The following is a description of a gene set: Mouse Gene Set: GOBP_PROTON_MOTIVE_FORCE_DRIVEN_ATP_SYNTHESIS species: Mus musculus The chemical reactions and pathways resulting in the formation of ATP driven by transport of protons across a membrane to generate an electrochemical gradient (proton-motive force)., and this is the list of marker genes: Ndufa1, Ndufab1, Ndufa7 (NADH:ubiquinone oxidoreductase subunit A7), Ndufa10, Ndufa6, Ndufb9, Sdha, Atp5mc2, Atp5f1e, Ndufb8, Ndufs2, Ndufv1, Ndufa12, mt-Nd2, Ndufb10, Ndufs1, Ndufs8, Ndufb6, Atp5f1a, Atp5f1c, Atg5lrt, Sdhc, Ndufa2, Atp5mc1, mt-Nd1, Ndufs5, Atp5f1d, Ndufs3, Ndufb5, Atp5pb, Ndufb1, Ndufa11, Ndufs4, Ndufc2, Ndufa3 (NCBI Gene Id 72213), Ndufs6, Ndufb2, Sdhd, Atp5me, Sdhb, Atpsckmt, Atp5po, Antkmt, Atp6v1a, mt-Atp8, mt-Nd4, Stoml2, Ndufb7, Atp5mg, mt-Nd5, Ndufb3, mt-Atp6, mt-Nd4l, Ndufb4, Ndufc1, Ndufa9, Ndufa8, Ndufa5, Atp5if1, Atp6-ps, Ndufa13, Atp5pf, Atp5f1b, mt-Nd6 (NCBI Gene Id 17722), Atp5mc3, Dnajc30, Ndufv3 (NADH:ubiquinone oxidoreductase core subunit V3), Atp5mf, Ndufb11, Ndufv2, Ndufs7, Atp5pd, mt-Nd3